The following is a description of a gene set: studied in species Homo sapiens In this module, the biology of various types of regulatory non-coding RNAs are described. Biogenesis and functions of small interfering RNAs (siRNAs) and microRNAs (miRNAs) are annotated. Biogenesis of PIWI-interacting small RNAs (piRNAs) and tRNA-derived small RNAs (tsRNAs) are also annotated. Reactome Pathway: Gene Silencing by RNA part of: Gene expression (Transcription), and this is the list of marker genes: TDRD9, TDRD1, TRH-GTG1-1, AGO2, TRL-TAG1-1, H3-3A, POLR2F, H2AC7, H2AC20, TRP-TGG1-1, MYBL1, POLR2J, H2AX, H2AZ2, POLR2K, TRV-CAC1-1, TARBP2, H2BC3, H2BC14, PRKRA, POLR2G, DROSHA, H2AC4, H2BC12L (H2B clustered histone 12 like), HENMT1, TRG-CCC1-1, H2BC11 (H2B clustered histone 11), H4C1, TRE-CTC1-1, TRL-CAG1, IPO8, TRR-CCG1-1, TRI-TAT1-1, H2BC5, DDX4, TNRC6C, TNRC6A, TRD-GTC1-1, H2AC18, H2BC21 (H2B clustered histone 21), H2AC14, MOV10L1, PLD6, MAEL, TRP-AGG1-1, ANG, AGO3 (argonaute RISC catalytic component 3), TRG-GCC1-1, POLR2B, TRK-TTT1-1, POLR2C, TRS-GCT1-1, H2BC26, PIWIL1, POLR2I, POLR2H, H2AC6, TRS-CGA1-1, TRR-ACG1-1, POLR2L, MIR23B, POLR2E, TRE-TTC1-1, POLR2D, DICER1, H3C1, H2AB1 (NCBI Gene Id 474382), H2BC9 (NCBI Gene Id 8345), TNRC6B (NCBI Gene Id 23112), TDRKH (NCBI Gene Id 11022), TDRD12, RAN (NCBI Gene Id 87046), PIWIL2, BCDIN3D, TRA-AGC1-1, H2BC12, FKBP6, DGCR8, TSNAX, TRA-CGC1-1, H2BC13, H2AJ, ELAC2, H2BC15, TDRD6, TRQ-CTG1-1, PIWIL4, H2BC4, TRV-AAC1-1, POLR2A, TRM-CAT1-1, H2BC17, TRK-TTT3-1, AGO1, HSP90AA1, H3C15, TRA-TGC1-1, ASZ1, TRV-TAC1-1, MIR145, AGO4, TSN, XPO5, H2BC1